The following is a description of a gene set: studied in species Homo sapiens Human Gene Set: DUTERTRE_ESTRADIOL_RESPONSE_6HR_DN Genes down-regulated in MCF7 cells (breast cancer) at 6 h of estradiol treatment. from publication Dutertre M, Gratadou L, Dardenne E, Germann S, Samaan S, Lidereau R, Driouch K, de la Grange P, Auboeuf D (PMID 20406972) Alternative promoters (AP) occur in >30% protein-coding genes and contribute to proteome diversity. However, large-scale analyses of AP regulation are lacking, and little is known about their potential physiopathologic significance. To better understand the transcriptomic effect of estrogens, which play a major role in breast cancer, we analyzed gene and AP regulation by estradiol in MCF7 cells using pan-genomic exon arrays. We thereby identified novel estrogen-regulated genes (ERG) and determined the regulation of AP-encoded transcripts in 150 regulated genes. In <30% cases, APs were regulated in a similar manner by estradiol, whereas in >70% cases, they were regulated differentially. The patterns of AP regulation correlated with the patterns of estrogen receptor alpha (ERalpha) and CCCTC-binding factor (CTCF) binding sites at regulated gene loci. Interestingly, among genes with differentially regulated (DR) APs, we identified cases where estradiol regulated APs in an opposite manner, sometimes without affecting global gene expression levels. This promoter switch was mediated by the DDX5/DDX17 family of ERalpha coregulators. Finally, genes with DR promoters were preferentially involved in specific processes (e.g., cell structure and motility, and cell cycle). We show, in particular, that isoforms encoded by the NET1 gene APs, which are inversely regulated by estradiol, play distinct roles in cell adhesion and cell cycle regulation and that their expression is differentially associated with prognosis in ER(+) breast cancer. Altogether, this study identifies the patterns of AP regulation in ERGs and shows the contribution of AP-encoded isoforms to the estradiol-regulated transcriptome as well as their physiopathologic significance in breast cancer., and this is the list of marker genes: CTNND2, GALNT10, EFNA1 (ephrin A1), ITGB6, ZNF704, CDYL2, HSD17B11, CRISPLD2, UTRN, LIPH, RCAN1, INPP5J, PLA2R1, HCAR1, KLHL24, SGCG, RAB27B, ALCAM, NUAK1, LIMA1, FAM171B, LRATD1, DNAJC15, TMTC2, TGFB2, ATP6V0A4, CREBRF, TFPI, KAT2B, IRF6, BLNK, MMP16, ZDHHC7, N4BP3, GRHL3, CRYBG1, SH3BP4, MTAP, RNF144B, TSPAN12, STON1, NEDD4L, EPB41L5, FGF13, PLIN2, NR3C1, NPHP3, ERBB2 (erb-b2 receptor tyrosine kinase 2), CDKL5, BAK1, TP53INP1, CDK6, AHNAK2, S1PR3, ABCC5, EGLN3, NBEA, SESN3, GRB7, NPNT, PTGER4, KIAA0513, EFEMP1, DRAM1, SALL4, IL1R1, TGFB3, PLEKHF2, MYO1B, BMF, ACAA2, ARID5B, PARP9, HPS3, MME (membrane metalloendopeptidase), SSBP2, KYNU, ERBB4, LMO7, TMEM45B, ZNF467, CCNG2, TNS3, GRB14, EPAS1, UACA, CLEC2D, RND1, EFHD1, ST8SIA4, YPEL3